Given this list of marker genes Glb1l3, Rad51d, Elk3, Lrp11, Zfp26, Wasl, Plekha7, Slc26a3, Frmpd4, Marchf6, Svip, Elavl4, Rbms1, Gatc, Unkl, Cacna1g (NCBI Gene Id 12291), Kcnj15, Gopc, Cth, Gpnmb, Srsf1, Zfp91, Vim, Traf3, Smc5, Abcb11, Nqo2, Dhx16, Gspt1, Hsf2bp, Fam168b, Ppp6r2, Zfp763, Msi2, Nipsnap3b, Efemp1, Cpeb3, Fubp3, here is a description of the gene set: Genes predicted to be targets of miRBase v22 microRNA mmu_miR_28a_3p in miRDB v6.0 with MirTarget v4 prediction scores > 80 (high confidence targets). from publication Chen Y, Wang X (PMID 31504780) Mouse Gene Set: MIR_28A_3P studied in species Mus musculus